The following is a description of a gene set: Abnormal facial shape An abnormal morphology (form) of the face or its components. studied in species Homo sapiens Human Gene Set: HP_ABNORMAL_FACIAL_SHAPE, and this is the list of marker genes: SCARF2, SOS2, GRB10, NEU1, PIGB, CLCF1, DPH2, ELN, TAOK1, WARS2, NKX2-5, ATR, CRLF1, CHRNG, SLC35C1, SLC17A5, MAB21L1, MEIS2, DSTYK, TBR1, RAP1GDS1 (Rap1 GTPase-GDP dissociation stimulator 1), AKT1, SEPSECS, RPS6KA3, BUD23, RFWD3, MAP2K1, FLT4, ABCA5, PUS3, FARSA, SOX4 (NCBI Gene Id 6659), ANTXR2, SLCO2A1, DNAJC30, FMR1, PPP3CA, LAS1L, GALNT2, TMEM138, PPP2R5D, FBXO11, MPLKIP, CREBBP, FANCD2, IFT74, SOS1, THPO, CDK13, PEX16, OCRL, CLCNKB, SLC2A10, COL3A1 (collagen type III alpha 1 chain), PIGN, OCA2, AP1S2, FGFRL1, CACNA1C, DACT1 (NCBI Gene Id 51339), DCHS1, HSD17B10, CLCN3, PRMT7, SLF2, CFL2, TNNT1, SETD2, GJB2, ZNF423, SMARCC2, TMEM147, ITCH, ACBD6, ASXL1, ACTG2, RECQL (NCBI Gene Id 5965), AGT, PAICS, SOX6, TAPT1, ARID2, MID2, INPP5E, HSPG2 (heparan sulfate proteoglycan 2), SLC25A24, RAD51C, PTCH2, TSEN2, PIGO, STAT3, LIG4, GHR, PIGW, B9D2, BUB1B, SPRED1, MTRFR, SCUBE3, DLK1, SLC12A6, IQSEC2, BAZ1B, NFIB, ARID1A, ITPR1, GP1BB, ATP7A, SMC1A, KMT2C, SMS, RYR1, RAD21, LAMTOR2, HYLS1, PAX2, KAT5, SOX9, XRCC4, KIAA0586, NSD1, IDH2 (isocitrate dehydrogenase (NADP(+)) 2), RTL1, CEP41, EMC10, TMEM270, TP53RK, GJA5, TCOF1, CHRNE, HMGA2, ASXL2, GDF5, CPLX1, SH3PXD2B, IRF6, DHX9, PROP1, POLD1, TSEN34, HNRNPH1, SOX11, GNS, XYLT1, KLHL41, AFF4, ZNF711, POLR1D, BCOR, TMEM53, SMAD2, FBXL4, MOCS2, CTDP1, GTF2IRD1, RIN2, HGSNAT, RUNX2, CRTAP, PEX10, STRADA, ITGA7, PAK3, LEMD2, CAV1, TBL2, UBE3A, MAD2L2, UBA1 (ubiquitin like modifier activating enzyme 1), TBC1D24, HCCS, POR, MAF, TMEM67, LMOD3, CUL7, SSR4, KMT2D, USP48 (NCBI Gene Id 84845), THSD1, MTX2, ARSK (arylsulfatase family member K), SIM1, CCBE1, POLR1C, MEGF8, TBC1D7, DNA2 (NCBI Gene Id 1763), CTBP1, GTF2IRD2, TSEN15, TRIP13, MEG3, CDC42BPB, MYPN, TWIST1, TSPAN7, ETFA, BRWD3, CUX1, CDKN1C, MMACHC, ALMS1, FANCI, ZMPSTE24, SKIC3, AARS1, SEC24C, PEX2, NDUFB11, MTOR, PLOD2 (NCBI Gene Id 5352), KCNJ1, CLTCL1, PEX5, RNF135, RMRP (NCBI Gene Id 6023), CCDC8, BPNT2, POLD3, ZSWIM6, SNRPN, DNMT3B, RAD51, GTF2E2, AP4S1, BRAF, CAVIN1, FKBP10, C2CD3, SNX14, FLNA, EDARADD, SALL4, KCNA1, NOG, EXOSC9, FIBP, ABCC9, NDE1, SUMF1, POLR3A (NCBI Gene Id 11128), MAPK8IP3, CDH11, ECEL1, FAT4, GALNS, DOCK3, ALKBH8, HOXD13, TUBG1, SYT2, ALG1, PTH1R, RERE, KCNK9, SPEG, RIC1, ATRIP (ATR interacting protein), HACD1, SMAD3, HNRNPK, LTBP1, SLC18A3, TCTN2, SPECC1L, POLA1 (NCBI Gene Id 5422), PAX1, SPRED2, IGF2, GNE, RBL2, TCF20, ALG6, MANBA, RAD50, REN, LTBP3, ACTA1, TOPORS, ETFDH, THOC6, ADGRG1, MPDZ, MGP, RASA2, STX16, PRKACA, LHX4 (NCBI Gene Id 89884), KMT2A, FAM149B1, SMARCE1, FANCB, SLC2A2, CDK10, PAX9, CBL, FLNB, SRD5A3, LRPPRC, COG7, TAF1, CNTN1, MAP3K20, HRAS, NUP107, FAR1, NSUN2, NKX2-1, PTF1A, PDHA1, MPL, NEXMIF (NCBI Gene Id 340533), TRIM37, P3H1, ANKRD17, CLIP2, JAK3, KDM4B, AGA, AKT2, SERPINH1, CHST14, CUL4B, B3GAT3, ETFB, PEX14, PHF21A, TBX1, RPS29, TBC1D2B, MOGS, SLC25A12, SLC9A6, PEX13, AP2M1, RAB39B, PIGA, ELMO2, BMP1, BMP4, CLCN4, MIR17HG, ACER3, MGAT2, SCN1A, HEXB, TUBB, HDAC4, PAX7, KBTBD13, SON, AEBP1, HPGD, SET, CHD4, PLAG1, ALG8, OTUD5, DYM, PTCH1, LEMD3, GFRA1, FOXE1, GDF6, TAFAZZIN, BAP1, GRIN2A, UBE2A (ubiquitin conjugating enzyme E2 A), SP7, PAX8, EFEMP2, GRHL3, PAM16, MAN2C1, TBX22, RUSC2, SUMO1, IDUA, OTUD6B, NR3C1, CEP104, FANCE, FLI1, SALL1, INSR, MRPS34, LAMB2 (NCBI Gene Id 3913), AASS, PGM3, SH2B1, RRAS2, AP4B1, DNMT3A, TNNT3, ATP6V1A, FILIP1, NSDHL, USP9X, GUSB, PHIP, NSD2, NIPA2, PIGU, NPHP3, HS2ST1, TPRKB, DDX3X, CWC27, METTL27, KAT6A, CHRNB1, H19, SLC39A8, BRAT1, MRAS, FBXO31, HERC1, ZNF699, PLK4, CHAT, ALG12, BBS2, EYA1, RDH11, MVK, PORCN, MYO9A (myosin IXA), SOST, RAB33B, MAN1B1, MOCS1, KMT2E, NOTCH2, CTNND2, FBN1, SPTBN1, PEX26, BCAP31 (NCBI Gene Id 10134), ADARB1, HS6ST2, PCNT (NCBI Gene Id 9346), FRA10AC1, BUB1, CAMK2G, COX7B, WNT5A, TMEM260, TGFBR1, PIGQ, AP4M1, PIK3R1, KDM5B, GJC2, GFPT1, PHF8, TOR1A, SOX5 (SRY-box transcription factor 5), RFC2, PSMD12, TPM3, AMMECR1, NFIX, POLR1B, TDP2, BRPF1, PPARG, B9D1, PIK3CD, CAMTA1, PEX1, ARL3, IFT56, DCPS, PTRH2, WRN, ANGPT2, ADAMTSL2, PCGF2, SOX18, ASPH, LMBRD1, SYNE1, NIPA1, CHRND, FTO, ITGA8, EPG5, PDHB, RPGRIP1L, PRPS1, CNP, PALB2, COG2, CDC42, TOGARAM1, STEEP1, ACTB, TNPO2, PEPD, SEC61A1, COL9A3, NECTIN1, PHGDH, CPSF3, UHRF1, RNF113A, WNT10A (NCBI Gene Id 93651), PAPPA2, FERRY3, RELN, MMP2, RAF1, SLC10A7, VPS37D, RNU4ATAC, HNRNPC, MYOD1, ARID1B, NANS, ARMC9, CDCA7, G6PC1, NGLY1, EXOC8, NTRK2, MCTP2, SLC9A7, CHRNA1, CC2D2A, KCNJ8, STUB1, RPL10, EZH2, EDA, BCR, HDAC8, FGFR3, SUFU, MRPS28, CENPE, NHS, PLCB4, FGF3, STT3A, EFEMP1, FANCG, TELO2, ATP6V1E1, NR2F1, UFD1, PRKAR1A, FN1, AIP, KIF4A, ACE, ATP10A, BRCC3, PYCR1, GJA8, GPC3, FHL1, C12orf57, MRPL12, SUZ12, EIF2S3, ZDHHC9, BUB3, PGAP3, EED, SLC37A4, CPLANE1, PEX3, RAB23, RFX7, CBY1, SATB2, L1CAM, SEC24D, SETD1B (SET domain containing 1B, histone lysine methyltransferase), TET3, PLXND1, COMT, GTF2H5, COL2A1, RTTN (NCBI Gene Id 284278), PRDX1, PDE4D, CACNA2D2, CSPP1 (NCBI Gene Id 79848), FANCC, IARS1, MEN1 (NCBI Gene Id 4221), HYOU1, SIX1, NDN, VPS33A, KIF22, CTCF, RAPSN, FKBP6, CTNNB1, COL11A1, DHX37, USP8, SLC25A1, PRKAR1B, SLC1A4, SMARCAL1, TTI2, TMEM216, ERCC8, AGO1, SLC2A1, PEX19, ESAM, CNOT1, FGFR2, TLK2, RAC1, ERI1, POU1F1 (POU class 1 homeobox 1), NBAS, ERMARD, SCN3A, ADAMTS3, KDM1A, SGCG, ERCC3, BCAS3, FGF9, ATP6V1B2, PPP1R12A, ATAD3A, HUWE1, MN1, JMJD1C, PAH, ERCC4, PRKACB, COQ4, CANT1 (calcium activated nucleotidase 1), CPE, ADNP, MACF1 (NCBI Gene Id 649183), LHX3, BIN1, DPF2, NHEJ1, PIGK, CEP55, SPOP, EXOC2, SNAP25, SPRTN, ZBTB18 (NCBI Gene Id 10472), PIBF1, RIT1, EHMT1, AIFM1, GNAI3, LYSET, MAGEL2, DEAF1 (NCBI Gene Id 105376508), KCNJ2, AGRN, ZEB2, KCNC3 (NCBI Gene Id 57363), GAD1, PAX3, FANCA, COG1, BCORL1, POGZ, RYR3, CNTNAP2, NCF1, OFD1, AMER1 (APC membrane recruitment protein 1), SYNGAP1, BRIP1, ANOS1, TCTN1, RFXAP, SCN4A, COG4 (NCBI Gene Id 25839), RREB1, PLOD3, PIK3CA, MED12L (NCBI Gene Id 57726), ALG9, FGD1, CEP152, GAS2, DNM1, CLCNKA, PCYT1A, RPS17, DDR2, RLIM, POC1A, APC, NALCN, SLC5A7, TGFA, RNF168, LMX1B, SLC26A2, ARSB, TMEM237, MED13L, EP300, TCTN3, BMPR1A, COL6A1, SLC4A10, UBAP2L, STAG2, COL9A2, CHST3, TRPM3, MMP14, PIGF, DPH1, FOCAD, SH3BP2, ZBTB24, CIITA, CEP290, PPIB, LIFR, MYCN, PEX6, SETBP1, EXTL3, EBP, YY1, FANCM, RRAS, CARS1, MKS1, NKX2-6, OSTM1, TRIP11, MYH8, TOMM7, RNASET2, BGN, IFITM5, TFE3, PUS7, CHAMP1, CHD7, SEMA3E, ATG7, ANTXR1, AGPAT2, ORC6, PDE6D, SF3B2, CCDC174, SLC45A1, CTSA, ZNF148, PURA, B3GALT6, WAC, LRP4 (LDL receptor related protein 4), CCDC115, TNRC6B, COLQ, SLX4, TRPS1, AHDC1, TECPR2, SMO, ROR2, CASK, EDNRA, IGF1, NAGLU, LARP7, TSEN54, HECTD4, ZIC1, PIGS, HMBS, RNF13, PSMB10, ACTG1, TTC5, FRAS1, PACS1, SLC16A2, DPM2, SEPTIN9, LONP1, GLB1, NPHP1, POLR1A, CHD2, RBBP8, ALG13, ERF, GJB6 (NCBI Gene Id 1897), USP7, MYSM1, H4C5, TSPEAR, POU4F1, PIEZO2, AP3B1, TALDO1, TRAIP, TCF4, TRIO, RFX5, PEX11B, ADAMTSL1, ADSL, DENND5A, MAP2K2, RAB5IF, NEDD4L, IDS, BRF1, RECQL4, KATNB1, CEP120, DVL1, KANSL1, AP4E1, CHSY1, WDFY3, PIEZO1, B3GLCT, CHRNA7, SNAP29, PKD2, SLC35B2, SGSH, NR4A2, TGFB1, NEUROG1, CRKL, MYL2, RHOA, GNAS, PUF60, SMARCD1, NMNAT1, NOTCH3, LRP6, CDC6 (cell division cycle 6), MID1, GNPTAB, FGF10, TTN, KLF13, TUBB4A, P4HTM, PIGV, TBX2, ARVCF, TUBGCP4, PSPH, HIRA, KIF7, KRAS, WDR26, PACS2, GRIN1, COL1A1, FLCN, FGFR1, MBD5, IDH1, DLL1, NRAS, NEB, VAMP1, APC2, PIGY, CEP85L, ARX, HPSE2, GDF3, TP63, SCO2, PPP1R15B (NCBI Gene Id 84919), BLM, GLA, TSHR, CCDC47, MICU1, TONSL, PYCR2, SEMA5A, LZTR1, AIMP1, KAT6B, TBCK, CRELD1, WWOX, OBSL1, FGF20, DDX11, KMT2B (NCBI Gene Id 9757), PITX2, SMC5, OPHN1, FANCF, ASAH1, COG3, CA2, KIAA0753, SEC31A, CEP57, GTF2I, CHN1, DIS3L2, NKAP, LMNA, NRCAM, PYROXD1, ATRX, ALDH18A1, FUCA1, DDX59, DNAJC19, SLC6A1, PTPN11, ARMC5, AUTS2, GMPPA, BCKDK, NAGA, CSGALNACT1, ANKH, COL13A1, SF3B4, ALG2 (NCBI Gene Id 85365), PTEN, EFNB1, HEPHL1 (hephaestin like 1), GNPTG (N-acetylglucosamine-1-phosphate transferase subunit gamma), CLIC2, MATN3, PLAA, KATNIP, DLG5 (discs large MAGUK scaffold protein 5), WNT10B, WNT7A, FLII (NCBI Gene Id 2314), TPM2 (NCBI Gene Id 7169), VPS11, SKIC2, JAG1, SIX5, SLC35A2, SRCAP, TMEM231, PPP1R21, COL1A2, PGAP2, INTS11, GPC4 (glypican 4), ERCC1, TMEM70, ALG11, ACADS (acyl-CoA dehydrogenase short chain), FIG4, PEX7 (peroxisomal biogenesis factor 7), CDH23, KCNH1, CDK8, NF1, BSND, SVBP, PHF6, GBA1, SIN3B, ARL13B, HESX1, GINS1, KNSTRN, LIMK1, SLC6A8 (solute carrier family 6 member 8), JARID2, ERCC6, ELOVL4, MAN2B1, GPR101, STX1A, TMEM94, MEOX1, AGTR1, PIK3C2A, EXT2, AXIN2, UNC80 (unc-80 homolog, NALCN channel complex subunit), AHCY, HIBCH, AHI1, RFXANK, PKHD1, CDH1, EDN1, PQBP1, TP53, TARS1, KCNQ1OT1, XRCC2, ERCC2, CCN2, KCNN3, LETM1, SIN3A, ADAT3, HDAC9, HELLS, TRMT5, IFT57, KDM6B, BRCA1, SELENON, PIGG, UBE2T, SMARCA4, MYH3, NKX6-2, BPTF, EBF3, GPC6, UBB, STXBP1, TBL1XR1, COL9A1, KCNJ5, PRKG2, MAP3K7, COL11A2, CTNND1, SLC26A4, MED12, TNNI2, BSCL2, EIF4H, SPEN (spen family transcriptional repressor), ITGA3, B4GALT7, PPP2R1A, CENPT, ZFX, TMEM218, PIGL, DYRK1A, PMM2, TRMT10A, ATP6V0A2, COL18A1, PCDHGC4, PAK1, TGFB3, ADGRG6, SMARCA2, B4GALT1, PEX12, MTM1, MCOLN1, STAG1, CAPRIN1, NFIA, ALG14, MSTO1, GJA1, BRCA2, IGF1R, MSX1, GLI2, MORC2, PPP2R3C, MAPK1, PDE11A, EMC1, NONO, UBE3B, ANKRD11, KCNQ1, SMARCB1, FANCL, RAI1, FOS, FBLN5, WDR81, PBX1, NAA10, NUP85, MAFB, TMCO1, MAPRE2, UPF3B, ZMYM2, RNU4-2, RBMX, SMC3, KLHL15, KIF15, DHX30, DCAF17, TRAPPC9